The following is a description of a gene set: studied in species Homo sapiens Human Gene Set: KEGG_MEDICUS_REFERENCE_TLR7_9_IRF7_SIGNALING_PATHWAY Pathway Definition from KEGG: (TLR7,TLR9) -> MYD88 -> (IRAK4+IRAK1) -> IRF7 => (IFNA,IFNB1) TLR7/9-IRF7 signaling pathway. Pathway ID: N00690. Pathway type: Reference. Pathway class: nt06517 TLR signaling., and this is the list of marker genes: IFNA5, IFNA8, IRAK1, IFNA6, IFNA13, TLR7, IFNA7, IRF7, IFNA2, IFNA10, MYD88, IFNA21, IFNB1, IFNA1, TLR9, IFNA14, IFNA4, IFNA17, IRAK4, IFNA16